Given this list of marker genes Glipr1l2, Gxylt1, Zfp326, Tardbp, Styk1, Akap5, Amot, Sgpp1, Rora, Bach2, Trip12 (thyroid hormone receptor interactor 12), Prl8a8, Trim60, Rragc, Pcsk6, Pramel3e, Chic1, Pcdh7, Zxdb, Liph, Metap2, Fat3, Tmem263, Iws1, Ildr1 (immunoglobulin-like domain containing receptor 1), Plppr4, Rapgef6, Frmd3, Cwc22, Epb41l3 (NCBI Gene Id 56528), Pramel3b, Fbn1, Znrf3, Sfpq, Pik3c2a, Fzd3, Top2b, Usp47, Pramel3c, Phf6, Piezo2, Nova1, Ddx60, Samd8 (NCBI Gene Id 68822), Tmem167, Zbtb2, Cd244a, Zfp711, Mfsd4a, Nap1l2, Pcdh15, Armc8, Pramel3a, Sestd1, Grhl1, Mmd, A130010J15Rik, Asxl3, Sntn, Rwdd1, Prl8a6, Il20, Tbc1d9 (TBC1 domain family, member 9), Bicd1, Htr2a, Cep19, Mysm1, Clec2m, Rgs2, Nox4, Tmem106b, Zfp955a, Tirap, Gde1, here is a description of the gene set: Mouse Gene Set: MIR_6398 from publication Chen Y, Wang X (PMID 31504780) Genes predicted to be targets of miRBase v22 microRNA mmu_miR_6398 in miRDB v6.0 with MirTarget v4 prediction scores > 80 (high confidence targets). studied in species Mus musculus